The following is a description of a gene set: Mouse Gene Set: GOMF_SODIUM_BICARBONATE_SYMPORTER_ACTIVITY studied in species Mus musculus Enables the transfer of a solute or solutes from one side of a membrane to the other according to the reaction: Na+(out) + HCO3-(out) = Na+(in) + HCO3-(in)., and this is the list of marker genes: Slc4a5, Slc4a8, Slc4a10, Slc4a7, Slc4a4, Slc4a9 (NCBI Gene Id 240215)